Given this list of marker genes APOE, NRG2, ADAP1, YAP1, RPS27A, ERBB4, S100B, SPARC, MXD4, GABRB2, PIK3CA, PIK3R1, STAT5A, ESR1, NRAS, SOS1 (SOS Ras/Rac guanine nucleotide exchange factor 1), GFAP, EGF, BTC, WWP1, UBA52, PSEN2, GABRG2, NCSTN, GABRA1, NRG3, GABRB1, CXCL12, UBC, ERBB3, ADAM17, ITCH, WWOX, SHC1, PSENEN, GRB2, EGFR, EREG, UBB, NCOR1, GABRQ, GABRG3, NEDD4, TAB2, DLG4, NRG4, PGR, NRG1, HRAS, GABRB3, APH1A, PSEN1, CSN2, APH1B, SRC, STMN1, HBEGF, KRAS, here is a description of the gene set: Signaling by ERBB4 studied in species Homo sapiens Human Gene Set: REACTOME_SIGNALING_BY_ERBB4